The following is a description of a gene set: Any process that stops, prevents, or reduces the frequency, rate, or extent of smooth muscle cell apoptotic process. Mouse Gene Set: GOBP_NEGATIVE_REGULATION_OF_SMOOTH_MUSCLE_CELL_APOPTOTIC_PROCESS species: Mus musculus, and this is the list of marker genes: Dipk2a, Nr4a3, Edn1, Mapk7, Lrp6, Agtr1a, Igf1, Slc7a5 (NCBI Gene Id 270102), Dnmt1, Stub1, Gsk3b, Cftr, Arrb2, Esr1, Gapdhrt2, Lypd3, Gapdhrt, Apoh, Map2k5, Gria4, Gapdh